Given this list of marker genes PHF21B, HIVEP2, PRKX, PCLO, HECW2, SCN9A, PPP2R5C, RBBP4, LUZP2, APC, RUVBL1, MORF4L2, HRNR, CLCN3, HDHD2, TFDP2, PPFIA1, GASK1B, CTDNEP1, RBM41, CACUL1, TULP4, TRPM1, FCHO2, ATG3, MED14, SEPTIN14, CEP20, HIPK3, TUBGCP3, DEPTOR, PRKD1, ZEB2, LGALS8, STK39, DNMT1, FAM76B, HFE, ERRFI1, USP46, FZD5, SCN3A, PRR16, ULK2, TBC1D8B, SAMD12, SYT1, APP, TXLNB, MED13L, RAB39A, HERC2, CLTC, PTPN12, SLC36A2, DCP2, TARDBP, RCOR1, PYHIN1, SLC4A4 (solute carrier family 4 member 4), UCKL1 (NCBI Gene Id 54963), MAGI1, GNG2, THAP6, AMD1, SESN3, WSB1, KIF20B, IGFBP5, LPP, TWIST1, PFN2, MRGPRX3, ZNF704, ACSL3, PON1, HSPA4L, ACSL6, CSPP1, NRG3, GCLC (NCBI Gene Id 2729), OLFM4 (NCBI Gene Id 10562), FBXL3, SH3TC2, BCL2L15, PDE4D, MED12L, IKZF2, MRE11, RAPGEF2, RAB2A (RAB2A, member RAS oncogene family), TOMM22, PAPOLA, ARFGEF3, RNF19A, PANK1, ZNF12, UQCC6, STRN3, ZNF703, ZNF230, CHTOP, CAMKK2, SBSPON, SESTD1, RAB33B (NCBI Gene Id 83452), PHTF2, SLC7A11, ROBO2, SH3KBP1, NETO1, BRWD3, NEXMIF, CLDN10, IL7R (interleukin 7 receptor), FAM120A, SALL1, ZFHX4, SLC1A6, CLIP3, AFF2, ABI1, ZNF503, GALK2, MEF2C (NCBI Gene Id 4208), UBQLN2, CFL2, CITED2, CCDC88A, ROCK1, FIRRM (FIGNL1 interacting regulator of recombination and mitosis), DCHS2, TMX3, SLC25A43, CDC42, SLF1, RIMKLB, ZNF516, SELENOT, RRS1, APBB2, PTPN4, HSPA2, ALDH7A1, GCG, NR2F2, DCAF8L1, ZNF485, RCHY1, PATJ, FLRT2, IGSF10, CNOT4, AXIN2, EFCAB7, IFIT5, MIER3, CNTNAP4, PCDH7, SYCP1, HARBI1, TNRC6B, MFAP5 (NCBI Gene Id 8076), WIPF1, CNOT1, THBD, CLTA, AGAP1, HADHB, MPEG1, LRP12, TRUB1, PICALM, POU4F1, PMP22, AFF4, PDCD2, SUMO3, BMAL1, BNIP2, STK38, ZFYVE9, COBL, PMCH, LPAR3, LIN7A, KLF3, SLC5A1, ETV1, IFT70B, ZNF384, TRPS1, PKN2, ZBTB21, PREX2, BRD10, TMEM178A, SUB1, UBE2E2, SOCS6, CERS3, GLCCI1 (glucocorticoid induced 1), LRCH2, CLPTM1L, NRK, CTSS, ZNF318, PIK3C2G, RNF146, GTF2H3, SRPK2, SHISA6, ZNF827 (NCBI Gene Id 152485), NFYC, C11orf71, ACVR1C, CNN3, RAB34, USP30, GPR139, NLRP8, HYDIN, CYSLTR1, UBAC2, GABRB2, ERC2, CCSER1, MYLK3, MORC3, UEVLD, SF3B1, VEZF1, KPNA3, DGKH, DICER1, STARD13, GALNT7, ZNF592, FUT9, NRBF2, ZNF202, LMO7, TMEM26, WDR3, PELI1, HYCC2, RAB21, C6orf118, EIF4E, TNFRSF11B, IKZF5, RAP1B, CLXN, GPM6A, LMO3, ADAM10, KCND2, ZNF148, TYRP1, PDE8A, FERMT2, ARB2A, SPRED1, RAB3B, BACH2, ZNF302 (NCBI Gene Id 82167), PTPRK, C3orf80, ZSCAN31 (zinc finger and SCAN domain containing 31), ARHGAP11A, LPGAT1, AMELX, EIF4H, OLFML3, DNALI1, ERGIC1, POF1B, PDSS2, MAFB, SMURF2, CTDSPL2, EML4, NOS1, ADAMTS6, DPY19L2, ANKRD40, DKK2, MBLAC2, IL20, RRAGC, SNX6, SLC12A2, SBNO1, LETM2, ELAVL4, TSHZ3, ZNF721, DYRK3, ABCD2, SLC10A7, PPP2R5E, ARID2 (NCBI Gene Id 57676), RPL22L1, PDP1, here is a description of the gene set: Genes predicted to be targets of miRBase v22 microRNA hsa-miR-5700 in miRDB v6.0 with MirTarget v4 prediction scores > 80 (high confidence targets). Human Gene Set: MIR5700 studied in species Homo sapiens from publication Chen Y, Wang X (PMID 31504780)